The following is a description of a gene set: Bcl6 germline deletion causes a prominent inflammatory disease, owing to over-expression of Th2 cytokines, and affects the properties of B cells prior to immunization. Therefore we established the B cell-specific Bcl6 deletion mice and analyze the gene expression of naive B cells under physiological conditions. Human Gene Set: GSE28737_BCL6_HET_VS_BCL6_KO_FOLLICULAR_BCELL_DN from publication Kaji T, Ishige A, Hikida M, Taka J, Hijikata A, Kubo M, Nagashima T, Takahashi Y, Kurosaki T, Okada M, Ohara O, Rajewsky K, Takemori T (PMID 23027924) Genes down-regulated in follicular B lymphocytes with BCL6 knockout: heterozygotic versus homozygotic strains. species: Homo sapiens, and this is the list of marker genes: LMF1, BGN, BCKDHA, GFPT2, CDK1, CNN3, HSD3B7, UGP2, PRPF38A, FKBP5, FKBP10, FUT7, PHLDA3, TENT5C, ZFYVE19, CD2, HAL, TGFBI, STXBP2, NECAP2, H3C14, ZBTB7B, TNC (tenascin C), FSTL1, ZFTRAF1, CYTH1, ZDHHC16, DHRS3 (dehydrogenase/reductase 3), HMGB2, AKIRIN1, ESYT1, BTD, PKIB (NCBI Gene Id 5570), ZBTB48, CHCHD10, LOX, PKIG, HEBP1, FXYD5, MGST2, PLAU, SPIN1, MIF4GD, NME3, MS4A6A, LAMTOR4, ZNF688, SNX1, TMEM37, MAP2, ADSS1, CYSTM1, MR1, CACNB3, FBLN2, CLK1, APOC2, DYNLT3 (dynein light chain Tctex-type 3), TXNDC5, FZD2, NTPCR, TSSK1B, LRRC57, FAM98A, MYH10, SEMA5B (NCBI Gene Id 54437), TIMP3 (NCBI Gene Id 7078), MRPS17, CCDC86, S100A8, SEPHS2, MRPL41, TMEM38B, APLP1, LTC4S, SPARC, RNASE4, IDS, ITGB5, CRX, RBMS2, CUTA, SETD4, BAD (BCL2 associated agonist of cell death), ELOVL3, GINM1, TM7SF3, ENPP1, ATRAID, FAM3C, S1PR1, POLDIP2, CSRP2, FERMT2, KLF10, TMEM268, DHRS7, YPEL3, CARM1 (NCBI Gene Id 10498), PYCR2, KRT72, CTSK, IPP, TPGS1, INO80C, RASSF2, KLK4, CDO1, BLTP3A, SPP1, SCARB2 (NCBI Gene Id 950), COL1A2, DICER1, ABCC3, RIN2, TBXAS1, PTP4A3, SLC31A1, RARA, FGB, GBP4, TCN2, ELL2, NECAP1, TST, CYBC1, PITX1, MYT1L, COPZ2, VRK3, PFKL, SLC7A7, CD276, SYT11, PPDPF, DUS1L, TULP4, SPHK1, BCL2L11, NOCT, TSPO, C9, FES, SIGMAR1, DDX41 (DEAD-box helicase 41), CTSH, TFPI2, RASIP1, COL1A1, PTGS1 (prostaglandin-endoperoxide synthase 1), ABCB1, C1QB, IL17RA, BSCL2, KDELR3, CD2BP2, GLI3, C1QA, SRPK2, HM13, COL6A3, ILKAP, RPL41, SERPINH1, RHOU, DNAJC8, FCGR1A, GABRR1, ANKH, GALK1, MSRB1, SOCS3, FKBP9, KCNJ3, NAA40, TUBG2, C1QC, CDK5RAP3, SALL4, PENK, MYEF2, METTL9, RASD1, CDR2, RIT2, CCN4, DCPS, VKORC1, DAD1, GSTO1, TMED4, SMAD7, RBP1 (NCBI Gene Id 5947), MAL, LY86, TOMM34, ZNF398, MAT2A, SNAP91, SAT1